The following is a description of a gene set: species: Homo sapiens SIRT1 negatively regulates rRNA expression Human Gene Set: REACTOME_SIRT1_NEGATIVELY_REGULATES_RRNA_EXPRESSION, and this is the list of marker genes: H2BC15, H2BC13, H2AC6, H4C1, H4C2, H2BC10, H3-3B, H4C6, H3C14, SIRT1, H2AZ2, H4C4, H3C12, H2AC19, H3C10, H3C2, H2AC4, H4C14, H2AJ, H2BC8, H2AC7, H4C9, H3C11, H4C16, H2AX, H4C8, H2BC5, H3C3, H3C13, H2AB1 (NCBI Gene Id 474382), H2AC14, H3-3A, TAF1C, H3C1, H2BC12, H4C11, H2BC11, H4C12, H2AC20, H4C3, RRP8, H3C6, H4C5, H2BC21, H2BC9, H2BC3, H2BC17, H2BC12L, H3C15, H3C4, H3C8, H2BC4, TAF1B, H2AC8, TAF1A, TAF1D, H2BC1, H2BC6, H4C15, H2AC18 (H2A clustered histone 18), H2BC7, H2BC26, TBP, H2BC14, SUV39H1, H3C7, H4C13